The following is a description of a gene set: studied in species Mus musculus Binding to a heterotrimeric G-protein. Mouse Gene Set: GOMF_HETEROTRIMERIC_G_PROTEIN_BINDING, and this is the list of marker genes: Cetn4, Drd1, Drd2, F2rl1, F2r, Cetn2 (centrin 2), Adora1, Adra2a, Cetn1